The following is a description of a gene set: Genes containing one or more binding sites for (RPA2) in their promoter regions (TSS -1000,+100 bp) as identified by GTRD version 20.06 ChIP-seq harmonization. species: Homo sapiens from publication Yevshin I, Sharipov R, Kolmykov S, Kondrakhin Y, Kolpakov F (PMID 30445619) Human Gene Set: RPA2_TARGET_GENES, and this is the list of marker genes: MTCO3P12, TIMM44, DDX11L5 (DEAD/H-box helicase 11 like 5 (pseudogene)), MTND6P4, DDX11L17, LINC02684, MTCYBP18